The following is a description of a gene set: studied in species Homo sapiens Cyclopia is a congenital abnormality in which there is only one eye. That eye is centrally placed in the area normally occupied by the root of the nose. Cyclopia Human Gene Set: HP_CYCLOPIA, and this is the list of marker genes: CDON, SIX3, PRRX1, STAG2, FGF8, FGFR1, GAS1, DISP1, PTCH1, FOXH1 (forkhead box H1), DLL1, SMC1A, OTX2, PLCH1, CRIPTO, STIL (NCBI Gene Id 6491), NODAL, SHH, TGIF1, SUFU, GLI2, ZIC2